Given this list of marker genes FOXO1, ARHGEF12, RASGRP1, SYNJ2BP, ST6GALNAC1, UTRN, PHAF1, REPS2, GANC, IL7R, ITPKB, ZCCHC24, SLC49A4, STAU1, SMLR1 (NCBI Gene Id 285733), ACBD5, NETO2, TBC1D2B, ERAP1, CYB5A, PDE8B, TGFBR2, CREB5, ZCCHC14, ASPH, MAP3K4, HSPA12A, IL6ST, ARID2, TASOR2 (transcription activation suppressor family member 2), C6orf47, VEPH1, CA3, HECTD1, VSTM2A, PGRMC2, KATNBL1, GOLGA5, TAB2, SSH3, BAK1, TRIM6, ASH1L, EIF3M, ZNF644, LRRC59, ANKRD50, MPRIP, GPCPD1, CYP4X1, ZEB1, AK5, GNAL, TMTC2, PDZD2, NOL7, TESK2, GPRC5B, ITGAV, ACBD3, TAGAP, CIITA, JMJD1C, FUBP1, IPO7, KLF13, HAL, FBXO45, RAB2A, RAB12, OSBP, DMTF1, BTLA, UXS1, TBL1XR1, WASL, FAM13A, ZEB2, NR3C1, LPP, LRRC17, TWF1, ITGB8, SELENOI, ECI2, PPP1R37, GGA3, BMAL1, STAM, HTATIP2, CBLB, PRC1, SP4, ILDR2, NMBR, PTPN23, SNX16, CLOCK, MIER1, MARK3 (microtubule affinity regulating kinase 3), RICTOR, RREB1, here is a description of the gene set: from publication Chen Y, Wang X (PMID 31504780) Human Gene Set: MIR6073 Genes predicted to be targets of miRBase v22 microRNA hsa-miR-6073 in miRDB v6.0 with MirTarget v4 prediction scores > 80 (high confidence targets). studied in species Homo sapiens